Given this list of marker genes FGF17, NPTN, NRXN1, FGF18, FGF8, FGF23, here is a description of the gene set: Human Gene Set: GOMF_TYPE_1_FIBROBLAST_GROWTH_FACTOR_RECEPTOR_BINDING Binding to a type 1 fibroblast growth factor receptor (FGFR1). species: Homo sapiens